The following is a description of a gene set: Human Gene Set: GOBP_DNA_TEMPLATED_DNA_REPLICATION_MAINTENANCE_OF_FIDELITY species: Homo sapiens A DNA metabolic process that prevents or corrects errors to ensure that DNA is replicated accurately. Errors can be corrected either by intrinsic DNA polymerase proofreading activity or via mismatch repair., and this is the list of marker genes: BRCA2, ASF1A, PCNA, FANCM, POLD1, EXO1, POLG, RTEL1, CENPS, MRE11 (MRE11 homolog, double strand break repair nuclease), CAMSAP3, CENPX, DONSON, DYNLL1, ATR, TONSL, BARD1, ZNF365, ZRANB3, KHDC3L, BOD1L1, RECQL (NCBI Gene Id 5965), FBH1, DDX11, POLE, TIPIN, MUS81, OOEP (oocyte expressed protein), TIMELESS, RBBP8, SAMHD1, TRAIP, PRIMPOL, EME1, MCM8, PARP1, MMS22L, RAD51, SLFN11, WRN, CDK9, SETMAR, RAD50, SMARCAL1 (SWI/SNF related, matrix associated, actin dependent regulator of chromatin, subfamily a like 1), EXD2, FAM111A, CARM1, EME2, ETAA1, RFWD3, BLM, NUCKS1, DNA2, BRCA1, GEN1, MCM9, POLQ, NBN, ATRX